Given this list of marker genes ELK4, ADGRE5, TRIM41, SGK1, NXF1, PXMP2, IFFO2, DUSP11, STOM, SERPINA6, SPRED1, MACROH2A1, SRC, PLSCR1, PCYT1A, UTRN, RASSF8, CCL5, KCNE2 (potassium voltage-gated channel subfamily E regulatory subunit 2), RAD9A, C19orf25, HIF1A, CYSRT1, DUSP1, ZNF503, TRIM46, ZNF740, PAXBP1, NHSL3, PDE4DIP, IL17RC, KCNA2, GHITM, CCR1, SGCB, ARHGAP45, KIF9, ATMIN, JMJD1C, TMEM51, CADPS, KIF5C, MVP, PLEKHO1, NRBP1, MORC3, ARHGAP17, F10, BRDT, NMNAT1, PLEKHN1, NCOA3, MDM4, TIPARP, NET1, TSPAN13, FABP4, ASNS, VPREB3, APOBEC2, KAT2B, ZFAND2A, PLEKHA2, CMTM6, ORM1, IRF2, TMUB2, IP6K1, RTF2, SMG8, MS4A7, CRKL, BOD1L1, RRBP1, TAF7, SCAF4, SLC37A1, PACS2, RAB29, BST2, BATF2, SBF2, RIN2, LGALS3, ZNF334, ANXA11, DENND4C, CHFR, MAN2A1 (mannosidase alpha class 2A member 1), JARID2, NFKBIL1, CPT1A, GOLPH3L, RNF19B, JUNB, MTMR1, SDC3, ASIP, MALAT1, RNF114, TMCC3, CRIP1, AEBP2, ESS2, P2RX4 (NCBI Gene Id 5025), MTMR14, IL21R, PISD (NCBI Gene Id 29838), SATB1, RAB43, MYCL, DPYSL5, SRGAP2, PKIG, ANXA8, ZFP36L2, CLEC7A, APLNR (NCBI Gene Id 187), TDRD3, ECE2, STAT6, TSPYL1, CSF2RB, BAZ2B, CHCHD10, AP1M1, TMEM229B, ABCB1, ITCH, ITGB7, NR1H2, PIAS1, NCOA1, TRAF6, ENG (NCBI Gene Id 2022), SCN3A, IL7, CHRD, CHST10, CST3, LAT2, RBM17, ARL8A, MOCOS, TRPV4, CAMK2D, SLC25A28, ARRDC4, HTRA1, SCAMP2, CEP350, SLC22A17, PSD, ATF1, IL4I1, SPICE1, SUN2, OR51B2, PHF23, MLLT3, NKD2, PFKFB3, PSEN2, TAX1BP1, POMP, ITPA, DMTN, ANKRD44, MLLT10, RRAGC, RBMS2, MBD2, SERPINC1, RGS14, TLE2, FBXO6, SLC25A42, SRGN, ZNF277, MYH4, RNF115, MDFIC, BBX, SAT1 (spermidine/spermine N1-acetyltransferase 1), FAM89B, ILRUN (NCBI Gene Id 79138), TMBIM6, PSMD10, UNC50, CLP1, RHOU, MSRB1, CCL2, PRNP, H1-2, RBM25, RIPPLY3, WDFY1 (NCBI Gene Id 57590), TXNDC17, FANCI (NCBI Gene Id 751608), here is a description of the gene set: Human Gene Set: GSE17721_POLYIC_VS_GARDIQUIMOD_16H_BMDC_UP Genes up-regulated in comparison of dendritic cells (DC) stimulated with poly(I:C) (TLR3 agonist) at 16 h versus DC cells stimulated with Gardiquimod (TLR7 agonist) at 16 h. species: Homo sapiens mouse primary BMDCs were stimulated with tlr ligands and gene expression changes were profiled on Affymetrix arrays from publication Amit I, Garber M, Chevrier N, Leite AP, Donner Y, Eisenhaure T, Guttman M, Grenier JK, Li W, Zuk O, Schubert LA, Birditt B, Shay T, Goren A, Zhang X, Smith Z, Deering R, McDonald RC, Cabili M, Bernstein BE, Rinn JL, Meissner A, Root DE, Hacohen N, Regev A (PMID 19729616)